The following is a description of a gene set: studied in species Homo sapiens CD4 T cell help is critical for both the generation and maintenance of germinal centers, and T follicular helper (TFH) cells are the CD4 T cell subset required for this process. SAP (SH2D1A) expression in CD4 T cells is essential for germinal center development. However, SAP-deficient mice have only a moderate defect in TFH differentiation as defined by common TFH surface markers. CXCR5+ TFH cells are found within the germinal center as well as along the boundary regions of T/B cell zones. Here we show that germinal center associated T cells (GC TFH) can be identified by their co-expression of CXCR5 and the GL7 epitope, allowing for phenotypic and functional analysis of TFH and GC TFH populations. Here we show GC TFH are a functionally discrete subset of further polarized TFH cells, with enhanced B cell help capacity and a specialized ability to produce IL-4 in a TH2-independent manner. Strikingly, SAP-deficient mice have an absence of the GC TFH subset and SAP- TFH are defective in IL-4 and IL-21 production. We further demonstrate that SLAM (Slamf1, CD150), a surface receptor that utilizes SAP signaling, is specifically required for IL-4 production by GC TFH. GC TFH cells require IL-4 and IL-21 production for optimal help to B cells. These data illustrate complexities of SAP-dependent SLAM family receptor signaling, revealing a prominent role for SLAM receptor ligation in IL-4 production by germinal center CD4 T cells but not in TFH and GC TFH differentiation. Genes up-regulated in CD4 T cells: non-Tfh versus Tfh (T follicular helper) from germinal center. Human Gene Set: GSE21380_NON_TFH_VS_GERMINAL_CENTER_TFH_CD4_TCELL_UP from publication Yusuf I, Kageyama R, Monticelli L, Johnston RJ, Ditoro D, Hansen K, Barnett B, Crotty S (PMID 20525889), and this is the list of marker genes: SPTSSB, LPAR3, IFI30, FUZ, VSX1, KHK, WASF1, ARPIN, CCDC120, KLF12, PAK6, TMEM231, GPR75, ANKRD42, PLA1A, FNDC1, THTPA, HEY1, DUSP10, FGF14, GABRA5, PHLDA3, ACOT12, KLHDC7A, AK7, MPHOSPH8, TMC4, HAUS8, FIBCD1, BSND (NCBI Gene Id 7809), PMM2, NKX1-2, CRIM1, MICOS13, HEPH (NCBI Gene Id 9977), SMIM6, SH3D19, CPT1C, LTBP1, GJA8, COL1A2, FAM170B, IL17RC (interleukin 17 receptor C), SERPINB6, TNNI3, EYA3, KCNH7, RAB25, RAB30, MBD3L1, NECAB3 (N-terminal EF-hand calcium binding protein 3), CLCN2, DENND2B, TLE1, RSU1, ZNF266 (NCBI Gene Id 10781), HPCAL4, UBE2L3, CCDC136, PRCP (prolylcarboxypeptidase), ADAMDEC1, CC2D2A, DRC12, SCT, GSTM1, SCRN2 (secernin 2), MYO5B, USP14, TRAF2, MAP6, SPATS2, BHLHE40, NUDT18, C17orf99, TEKT2, TM7SF2, PLEK2, ADPRH, PRSS21, TPRN, FAM90A13, SCRN1, CRELD1, GFOD2, ZNF239, TDRP, XDH, F2, EHD3, GSTT1, EXOC3L4, TCEAL8, TH (NCBI Gene Id 7054), RENBP, OBP2B, BDH1, HYAL2, PODXL, KLHDC9, GK2, STRA6 (NCBI Gene Id 64220), CLIC3, TANC1, RALB, PRSS54, SALL3, SULT4A1, CD70, ZNF750, ALKBH5, ATP1A2, CELA3B, ICAM2, POLR1D, AK5, TMEM184A (NCBI Gene Id 202915), ITSN1, NRIP3, ICA1, TEAD2, SPIN4, SIK3, RAB13, ARHGAP5, ADORA2B, RASD2, RBMS2, EDA2R, LRRC3B, ECHDC2, SERPIND1, MFAP4, PSMA8, PORCN, ZNRF4, PLXNA2, PACRG, GAS2L1, C8G, RIPOR3, TBCB, CYB561, RHOJ, MPRIP, ZCCHC3, ARMC12, CISD1 (CDGSH iron sulfur domain 1), CCDC34, LONRF2, TSLP, CNTN3, ESS2, LPL, ZNF462, STK3, WWC2, SMAGP, PLAAT5, TMEM163, CAVIN3, LRRC28, E2F2, HSD3B7, NFATC2IP, TMEM158, PSRC1, CAVIN1, CD207, ACTN1, APLN, TEKT5, LAMC2, FKBP9, CYP17A1, HNMT, GZMH, IL36RN, C11orf65, CHRM3, GMPPB, FUOM (fucose mutarotase), IFT43, TTC23, TLX1, PLAC1, TFPI, ZSWIM1, EVC2, SPA17, CLU, DZIP1, CFAP107, LDHC, TP53INP2 (NCBI Gene Id 58476), DMRT2, USP54, SPDEF, ADAM23, ALAS2, CFAP157